Given this list of marker genes SPECC1, CFAP161, GPM6A, TOMM34, PAFAH1B1, FER, ZNF800, SPINDOC, ANKRD27, USP3, SLITRK4, NDUFAF7, CAT, EIF1B, SLC11A2, CDYL2, RASA1, ABCA6, CD55, PIK3R1, SLC10A7, HUS1B, SSB, SCAI, SGMS1, PDS5B, SOX7, TTC13, DDX52, UBE2D1, CLDN10, RBM12B, LARP7, KLF12, SPAST (spastin), CDKN1B, CCDC50, DNAJB9, GTF2A1, CNOT4, ZNF554, TP53TG3B, CEP85L, MED12L, NR4A3, AHNAK2, RCOR3, POLR3C, TAF4B, BRWD3, KDM3B, ERRFI1, CNTNAP1, SLF2, IDH3A, WASF3, ACACA, UBE2E2, NUDT15, AQP4, TIGAR, SSBP2 (single stranded DNA binding protein 2), MGME1, SLC4A4, TASOR, GPRASP2, ETV5, ERLEC1, MEIOC, RBBP4, LCOR, CEP83, ARL4A, GYG1, PAPPA, NCK1, STRBP, CRIM1, REST, CXXC5, PCDH9, H2BC21, MORC1, KIF1C, SLITRK1, GCFC2, LRATD2, ILF2, SLC25A31, TPD52L3, DOCK4, JADE1, LRRN1, ADH5, S1PR1, SPIN4, GPBP1, CCL28, ZBTB47, CLTRN, SSX2IP, MRPL2, GNPNAT1, PRR14L, ZNF254, DCAF5, TRMT11, PRKAA1, C15orf40, BCLAF3, DLG2, AMER2 (APC membrane recruitment protein 2), GATAD2A (NCBI Gene Id 54815), KDM7A, GET1, RNF180, MAP3K4, NFIL3 (NCBI Gene Id 4783), PHC3, SMG1, DNER (NCBI Gene Id 92737), GUCY1A2, ZEB1, RIC3, CPNE4, SETDB1, ASTN2, PRTG, ABCB5, KPNA1, MAP3K2, DPP10, PDE4D, KIF3C, SLC35E2B, ZFP28, SNAP25, ZNF678, SEMA4C, DTNA, DACH1, RBMS3, ZBTB1, RBM7, CHSY3, CRLF3, NUCKS1, HNRNPUL2, PTPN11, REPS2, KDM2B, SAMSN1, SPPL3, WDR45B, LRP11, SLC46A3, RIOK2, METAP2, ARL6IP5, SLC28A1, SCLT1, SHISA2, BCKDHB, ZWILCH, VPS35, ETS1, CLOCK, UNC5C, SMAD2, MCTS1, SLC25A36, MED21, SOX14, NPY5R, VPS50 (NCBI Gene Id 79604), NHLH2, ZMYM6, SEC23B, AVPR1A, GLS, CCNG2, CPLX1, HOXB8, PMEPA1, BROX, UGT8, CSTF2, PCDH20, HSPA12A, CDC42, BRD4, NSL1, PABIR2, PDP2, UBE2G1, TSPAN5, SRSF11, SLC7A11, PCDH11X, RAB18, FOXP1, CPEB3, NAPB, YIPF5, ZBTB20, ZDHHC20, SOX6, AZIN1, TLE1, LNPEP, RICTOR, TULP4, CYP27C1, APPBP2, LRP12 (LDL receptor related protein 12), CNTNAP2, PLK4, PHACTR2, BMP3, ZNF704, FOXF2, SNX30, ZNF292, ELF2, RELCH, CHM, CLCN3, DDC, SECISBP2L, CCN2, OR7A5, LAMP2, DNAJB14, ANO5, CRIPT, TMCO1, HNRNPLL, MORF4L2, JMJD1C, NKX2-1, NEUROD1, EFR3A, SDHA (NCBI Gene Id 6389), FAXC, COL4A4, SOX1, SPRYD7, LTF, CTNND1, MRPL19, GLCE, ACSL3, SMNDC1, AFF4, WAPL, KCTD9 (potassium channel tetramerization domain containing 9), NRP2, ZC3H12B, RUNX2, CCDC47, NLGN3, ATP6V1A, FCRL2, CCN3, SPATA13, DCAF8L1, ITGA1, IRF2BPL, FSD1L, JCAD, NOVA2, RPGRIP1L, TMEM192, HASPIN, CAMKK1 (NCBI Gene Id 84254), PDGFA, DUSP18, SLC9A6, MSI2, PAX9, THUMPD3, SMARCAD1, TCF4, ING3, SFXN2, SPAG11B, ARID4B (AT-rich interaction domain 4B), MYBL1, PKNOX1, HOOK3, WDR33, NALF2, ISCA1, TAOK1, HMGB1, SRSF7, TENT4B, SYT13, PPM1A, FZD5, PMFBP1, KDM2A, RAB1A, FCHSD2, PLEKHA8, SACS, UBL3, TM2D1, SLIT1, PTPN4, ASH1L, ST8SIA1, B3GALNT2, E2F3, ME1, GEMIN2, OSBPL11 (NCBI Gene Id 95889), WSCD2, NEXMIF, WDR44, GSE1, DCP1A, ARHGEF2, PPP4R4, MECOM, ZNF516, CCNT2, FUT9, ENTPD7, TMED2 (NCBI Gene Id 10959), NMU, GRIA3, TCEA1, MYB, RHOBTB1, PSD3, EPB41L5, VGLL4, KCNJ3, ZNF281, INTS2, ROR1, DCAF10, RLN2, WSB1, ZFR, MEIS1, HOPX, CHFR, ATXN1L, FAM98A, RALGDS, MPP7 (MAGUK p55 scaffold protein 7), MED28, NAP1L1, NUFIP2, PRKAR2B, U2AF2, SLC25A53, SUCO, RORA, SLC17A6, PRDM2, ELL, SLCO5A1, SON, KEAP1 (NCBI Gene Id 9817), ADRA1A (adrenoceptor alpha 1A), UVSSA, SCAF11, CEP104 (NCBI Gene Id 9731), RFX7, FBXW11, CA8, EI24, UBTF, TMEM207, DNMT3A, FCAR, ESCO2, PLEKHF2, ANXA4, ROCK2, KLF10 (NCBI Gene Id 7071), COL4A1, ENY2, SGIP1, ZBTB11, KHDRBS3, RPRD1A, UFM1, QDPR, ABCB7, EXOSC3, DCK, ZDHHC17, PIK3CB, OTUD4, BEND4, TP53TG3D, RAPGEF2, MTDH, MTMR4, COL19A1, PAFAH2 (platelet activating factor acetylhydrolase 2), UBE2W, DCUN1D1, EIF3A, CYREN, ZMYND11, RNASE6, ANK3, PYROXD1, ARRDC3, CREBZF, PEX3, FAM83A, ZNF92, VPS37A, PRDM1, E2F5, DCX, ETFBKMT, PUM2, ERAP1, C16orf46, TP53TG3, HECA, NELL1, NCBP3, LRRC25, KIAA2013, BPTF, HPS3, EPPK1, KPNA4, CHRNB1, STIM2, SYPL1, SLC25A32, CCDC28A-AS1, PHLDB2, CFAP126, CDK6, EDEM3, OPA1, CRACD, HNMT, ATG14, FOXC1, EGR4, RAB27B, CHORDC1, PLEKHA2, USP53 (ubiquitin specific peptidase 53), ATL2, ATP2B4 (ATPase plasma membrane Ca2+ transporting 4), BNC2, RBM20, TRIM6, RNF8, SLC7A6, TLE4, TOMM70 (NCBI Gene Id 9868), TIMM10, NPAT, here is a description of the gene set: studied in species Homo sapiens Genes predicted to be targets of miRBase v22 microRNA hsa-miR-3065-5p in miRDB v6.0 with MirTarget v4 prediction scores > 80 (high confidence targets). from publication Chen Y, Wang X (PMID 31504780) Human Gene Set: MIR3065_5P